The following is a description of a gene set: Transcriptional regulation of memory B cell differentiation studied in species Homo sapiens Human Gene Set: WP_TRANSCRIPTIONAL_REGULATION_OF_MEMORY_B_CELL_DIFFERENTIATION, and this is the list of marker genes: TLR4, CDKN2A, LYN, BCR, IRF4, BCL6, BCL2L1, CCND2, SLAMF1, CD79B, IRF8, CD79A, POU2F2, CDKN1B, IL21R, IL6, MEF2B, SPIB, CDKN1A, ID3, TLR3, TLR7, SYK, TCF4, NFKB1, ICOSLG, POU2AF1, IL4R, STAT6, TLR9, CCND3, TLR2 (NCBI Gene Id 7097), MYC, TNFRSF13C, TLR8, TLR1, TLR5, TLR10, SPI1, E2F1, TLR6, EZH2, MEF2C (NCBI Gene Id 4208), BORCS8-MEF2B, STAT3, TCF3 (transcription factor 3), CD40